Given this list of marker genes SLC28A2, SLC35B4, SLC35A3, SLC25A5, SLC5A6, SLC28A1, SLC35D1, SLC29A2, LCN9, SLC28A3, SLC27A4, SLC29A1, LCN1, ARL2BP, PDZD11, SLC29A3, APOD, LCN15, SLC29A4, ARL2, SLC25A4, SLC35D2, SLC35B3, LCN12, SLC35B2, SLC27A1, SLC25A6, SLC35C1, SLC27A6, SLC35A2, SLC33A1, SLC35A1, here is a description of the gene set: Reactome Pathway: Transport of vitamins, nucleosides, and related molecules part of: SLC-mediated transmembrane transport studied in species Homo sapiens This section groups the processes mediated by SLC transporters, by which vitamins and cofactors, as well as nucleosides, nucleotides, nucleobases, and related molecules cross lipid bilayer membranes.<br>The human SLC5A6 encodes the Na+-dependent multivitamin transporter SMVT. SMVT co-transports biotin (vitamin B7), D-Pantothoate (vitamin B5) and lipoic acid into cells with Na+ ions electrogenically.<br>Four SLC gene families encode transporters that mediate the movement of nucleosides and free purine and pyrimidine bases across the plasma membrane. These transporters play key roles in nucleoside and nucleobase uptake for salvage pathways of nucleotide synthesis, and in the cellular uptake of nucleoside analogues used in the treatment of cancers and viral diseases.<br>The human gene SLC33A1 encodes acetyl-CoA transporter AT1. Acetyl-CoA is transported to the lumen of the Golgi apparatus, where it serves as the substrate of acetyltransferases that O-acetylates sialyl residues of gangliosides and glycoproteins.<br>Nucleotide sugars are used as sugar donors by glycosyltransferases to create the sugar chains for glycoconjugates such as glycoproteins, polysaccharides and glycolipids. Glycosyltransferases reside mainly in the lumen of the Golgi apparatus and endoplasmic reticulum (ER) whereas nucleotide sugars are synthesized in the cytosol. The human solute carrier family SLC35 encode nucleotide sugar transporters (NSTs), localised on Golgi and ER membranes, which can mediate the antiport of nucleotide sugars in exchange for the corresponding nucleoside monophosphates (eg. UMP for UDP-sugars).<br>Long chain fatty acids (LCFAs) can be used for energy sources and steroid hormone synthesis and regulate many cellular processes such as inflammation, blood pressure, the clotting process, blood lipid levels and the immune response. The SLC27A family encode fatty acid transporter proteins (FATPs).<br>The SLC gene family members SLCO1 SLCO2 and SLCO3 encode organic anion transporting polypeptides (OATPs). OATPs are membrane transport proteins that mediate the sodium-independent transport of a wide range of amphipathic organic compounds including bile salts, steroid conjugates, thyroid hormones, anionic oligopeptides and numerous drugs (Hagenbuch & Meier 2004).